Given this list of marker genes PLOD1, COL1A1, PRKACB, SEC24C, LIMK1 (LIM domain kinase 1), RREB1, CLIP2, FKBP6, AHDC1, CSGALNACT1, EIF4H, GTF2IRD2 (GTF2I repeat domain containing 2), ERMARD, ERI1, STX1A, VPS37D, BAZ1B, CANT1, CREBBP, FLNA, TBX1 (T-box transcription factor 1), TBX4, RFC2, RBM8A, MAP1B, PIK3CA, GTF2I, NOTCH2, UFD1 (NCBI Gene Id 7353), BUD23, OCRL, PIEZO2, CHST11, MAB21L2, METTL27, ARFGEF2, DNAJC30, TMTC3, GDF5, FLNB, RYR1, KAT6B, NCF1, FZD2, RNU4ATAC, XYLT1, EBP, EP300 (E1A binding protein p300), GP1BB, ARF1, EXOC6B, SCARF2, COL5A1, YY1, SLC26A2, ARVCF, GTF2IRD1, HIRA, JMJD1C, ELN, TBL2, BPNT2, FBN2 (NCBI Gene Id 877), NEDD4L, PKDCC, WNK3, STXBP1, AEBP1, COMT, COL5A2, TMEM270, LMX1B, here is a description of the gene set: studied in species Homo sapiens The kneecap normally is located within the groove termed trochlea on the distal femur and can slide up and down in it. Patellar dislocation occurs if the patella fully dislocates out of the groove. Patellar dislocation Human Gene Set: HP_PATELLAR_DISLOCATION